The following is a description of a gene set: species: Homo sapiens Genes down-regulated in comparison of dendritic cells (DC) versus DCs exposed to B. malayi (5 worms/well). Monocyte-derived dendritic cells (DC) and macrophages (MΦ) generated in vitro from the same individual blood donors were exposed to five different pathogens, and gene expression profiles were assessed by microarray analysis. Responses to Mycobacterium tuberculosis and to phylogenetically distinct protozoan (Leishmania major, L. donovani, Toxoplasma gondii) and helminth (Brugia malayi) parasites were examined, each of which produces chronic infections in humans yet vary considerably in the nature of the immune responses they trigger. Human Gene Set: GSE360_CTRL_VS_B_MALAYI_LOW_DOSE_DC_DN from publication Chaussabel D, Semnani RT, McDowell MA, Sacks D, Sher A, Nutman TB (PMID 12663451), and this is the list of marker genes: PHB2, SYN1, KRIT1, DENND2B, ZFR2, COL1A2, MMP14, FCAR, PTGS1, ADAM15, F2, GRM5, RLBP1 (NCBI Gene Id 6017), EXT2, QPRT, PSMB2, UBE2S, C1QL1, MYL3, GRM4, GET3, RET, SULF1, MAX, MECOM, DOK2, CAMSAP1 (NCBI Gene Id 55490), HCRT, IRS1, DTNA, PDE4A, ADPRH, PADI2, BMP2, SLC16A1, LAIR2, CDK8, ADCYAP1R1, ERVW-1, GNB5, TDRD3, ZYX, FGFR4, KLF7, PTN (pleiotrophin), TRIO, CAPRIN1, UNC119, DSC2, OBSL1, PHKG1, AASS, TAGLN, RNASE2, CEACAM7, PHGDH, IL7R, COIL, MPZL1, MAPK8IP1, PHKA2, DOP1B, HRH1, PPP2R3A, CYLD, RPP40, AMHR2, SNAPC3, CR1, ATP6V0A2, MFAP3, IL23A, POM121L1P, ADSS2, MFAP2, PPFIA1, CILK1 (ciliogenesis associated kinase 1), FOXF1, CPNE6, FAT2 (FAT atypical cadherin 2), CX3CL1, CYP7B1, PDE1A, ADGRL2, RREB1, PARP1, MAPT, MSX1, RABEP1, PRKAR2A, CRHR1, LBP, UBE3B, PDE4D, TAF6L, FARP1, SIGMAR1, REG1CP, TFE3, KIF5C (kinesin family member 5C), MTSS2, CD7, SPINT3, CTF1, GNRH2, SALL2, INPP4A, SMIM10L1, ZNF37A, P2RY6, SLC35A3, ZNF280B, ATXN10, NPRL2, HDGF, ARR3, OVOL3, SFTPC, AMELX, CD93 (CD93 molecule), PTPRCAP, PLA2G15, KIF3A, PBX2, PENK, CDC42BPA, CCL23, TFDP2, ADGRB2, ZNF92, SF1, TNF, TRIM27, PLXNA3, SUSD5, OGFR, ATP6V1B1, TXNIP, MCAT, IRF8, EFEMP2, IBSP, PRKAB2, GPX2, KIAA0586, SLK, PITPNA, HSPH1, RBM4B, ANGPTL7, GH1, GNA13, CCNI, MDFI, FCGR3B, LCP2, COX7A1, SEMA3F (semaphorin 3F), SPINK4, APOD, RAP1GAP, POU1F1, PRSS3, PYGM, TRAPPC6A, APOBEC3C, IL10, SERPINA7, QPCT, CD160, MICAL3, MUC6, IKBKB, TENM1, HRG, DSP, MPZ, DLEC1, SYMPK, S1PR2, PAFAH2, GAB1, TMEM109, RPS6, FRY, BRCA2, DEGS1, CCNE1, CD34, PRRG1, KCND3, CDK13, ELL2, RRH, ZNF428, PPP2R1B, CD40, RFX2, NRG1, NT5C2 (5'-nucleotidase, cytosolic II)